Given this list of marker genes Lhx1, Cdh1, Csmd1, Errfi1, C3, here is a description of the gene set: The progression of the oviduct epithelium over time from its initial formation to the mature structure. An oviduct is a tube through which an ova passes from the ovary to the uterus, or from the ovary to the outside of the organism. The oviduct epithelium is the specialized epithelium that lines the oviduct. species: Mus musculus Mouse Gene Set: GOBP_OVIDUCT_EPITHELIUM_DEVELOPMENT